The following is a description of a gene set: Human Gene Set: WP_SCFA_AND_SKELETAL_MUSCLE_SUBSTRATE_METABOLISM studied in species Homo sapiens SCFA and skeletal muscle substrate metabolism, and this is the list of marker genes: SLC2A4, PYY, PPARD, FFAR3, FFAR2, GCG